Given this list of marker genes ZNF513, DMD, CREB5, PKP3, CHST11, LRMDA, NEUROD1, HOXC13, ZNF532, CSDE1, ZDHHC21, IFRD2, EXOSC9, TRMT10A, LIN54, RNF212, ATXN1, CTRC, CABP1, MAP4K3, MRPS18B, LMO1, CCN2, GRIK3, PRKCSH, LMOD3, C22orf31, ATAD2 (ATPase family AAA domain containing 2), CYB5D1, HSPB2, IPO7, MPZL3, TMEM88 (NCBI Gene Id 92162), EGR2, JMJD1C, TUG1, FKBP2, DNAJC5B, CCDC88A (coiled-coil domain containing 88A, NCBI Gene Id 731560), NR5A2, MEIS1, ZKSCAN5, CLUH, UBXN10, SLN, SMAD1, EMID1, GLYR1, MITF, USP3, LIN28A, MED12, HCN1, PLXNA2, PLAT, DDX17, OVOL1 (ovo like transcriptional repressor 1), GPHN (gephyrin), CHD2, FRA10AC1 (FRA10A associated CGG repeat 1), NSMCE3, HPN, SAT1, CHST10, SERPINC1, ODAD3, MBNL2, EML3, SRSF6, PRRX1, ZNF70, HBE1, ITIH2, PAGR1, CYTH3, ADO, SUPT16H, BNC2, LRCH1, MANF, ARL4A, XYLT1 (xylosyltransferase 1), IKZF2, VASN, ATP1B1, FOXD3, AKAP3, TMEM125, MICALL2, NR3C2, IMPG1, WFIKKN2, MPP2, CA14, JADE2, AFF4, SMAD3, SP8, FGF11, NLK, DIP2B, GRIA3, FGR, RARG, ZCCHC12, COPG2, HOXD9, FBRS, APP, FTCD, LRRTM3, CDK2AP1, SOCS2, PITX2, MACF1, PYGL, SYTL2, IL10, ABCC4 (ATP binding cassette subfamily C member 4 (PEL blood group)), ZDHHC7, CABLES1, AMY2B, VPREB3, DARS1, CSRNP3, CDK15, LMO4, FABP6, SLC32A1, NRG1, NR4A3, ALDH1A2, NAA38, RWDD3, CACNB3, FSTL1, AKIRIN2, SLC6A6 (solute carrier family 6 member 6), TAL1, TOB2 (transducer of ERBB2, 2), ITSN2, SLC18A2 (solute carrier family 18 member A2), BTF3P11, IL1RAPL1, GAP43, ZNF768, TAOK3, ITIH3, MAP1A, NXPH3, MLLT6, MAP4K4, CACNA1G, SIX1, BMAL1, CDK13, PLCD4, PRSS35, NLGN3, BMI1, GSK3B, BHLHE22 (NCBI Gene Id 27319), PURA, CDH10, FFAR4, ARHGAP18, TNFSF15 (NCBI Gene Id 9966, TNF superfamily member 15), NR2C2, HTN1, CNTF, AP1G2, STAC2, NUFIP2, PRSS12, MEIS2, ETV4, C4orf3, NDRG2, PTPRC, BRINP3, CKS1B, SLC38A6, BDNF, GRIN2B, SSBP3, MAP2K5, SMAD6, NPAS2, PLEKHA1, NR0B2, BCL9, DLGAP4, PSME1, ADAM15, HOXA10, PRKACA, RAMP2, GTPBP1, HOMEZ, TBCC, DRG1, ASB4, MYH13, TNS1, FHL3, APOA5, MSX2, DHRS3, HEBP1, OXA1L, RAB5C, TUT1, HMG20A, SEMA4A, NOL4L, SHC1, GATA4, KCNMB2, NYX, ARHGAP15 (Rho GTPase activating protein 15), IL11RA, KLF7, NRP1, SYNGR1, PTCHD4, KLK13, PLCG2, KRT25, UBE4B (ubiquitination factor E4B), CNIH2, BHLHE40, C6orf62 (NCBI Gene Id 81688), RNF145, ROM1, CNIH3, CCDC141, HOXD3, RPS6KA5, SCRN1, UGP2, KLHL11, NDN, CDK2, EDC4, HES1, NRXN3, GDI1, RREB1, ATRNL1, ALDOA, SOD3, ANGPT2, IL11, TTYH1, HES7 (hes family bHLH transcription factor 7), FAM50A, MDP1, ETV5, SCNN1A, DNAJC28, here is a description of the gene set: Human Gene Set: PXR_Q2 Genes having at least one occurrence of the motif RRGGTYANTRNM in the regions spanning 4 kb centered on their transcription starting sites. This matches the NR1H4 transcription factor binding site V$PXR_Q2 (v7.4 TRANSFAC). studied in species Homo sapiens